The following is a description of a gene set: Human Gene Set: GSE3982_EOSINOPHIL_VS_CENT_MEMORY_CD4_TCELL_DN studied in species Homo sapiens Genes down-regulated in comparison of eosinophils versus central memory CD4 T cells. from publication Jeffrey KL, Brummer T, Rolph MS, Liu SM, Callejas NA, Grumont RJ, Gillieron C, Mackay F, Grey S, Camps M, Rommel C, Gerondakis SD, Mackay CR (PMID 16474395) In the present study we used Affymetrix oligonucleotide microarrays to produce gene transcription profiles for the major leukocyte types in humans. This comprehensive dataset enabled us to not only establish which genes were expressed in each leukocyte type, but also which genes were expressed in each subset after activation. The used of a comprehensive dataset of gene profiles from all the major human leukocyte subsets enabled a novel and powerful means for identification of genes associated with single leukocyte subsets, or different immune paradigms., and this is the list of marker genes: PHB1, CUL4A, ZNF32, RAB40A, TMEM62, CETP, THAP12, CCHCR1, COX16 (cytochrome c oxidase assembly factor COX16), MALT1, GFOD3P (Gfo/Idh/MocA-like oxidoreductase domain containing 3, pseudogene), ABCA3, IL27RA, CMTR1 (cap methyltransferase 1), ANXA6, GIMAP6, NOC3L, SKIC3, POLI, RPS17, TRIM46, USP21, DPP4, UBE4B, CLUAP1, PELP1, HSP90AA1, DOCK9, CAPNS1, APBB1, MCM3, CBLB, ITGB1, SDC4, ADD3, CD38, TMSB10, COQ3, IL17A, TCF12 (NCBI Gene Id 6938), MRPL39, PKD1P1, RACK1, UQCRC2 (ubiquinol-cytochrome c reductase core protein 2), CASP8AP2, IL10RA (NCBI Gene Id 3587), RABGAP1, PFAS, KPNA6, CASK, DPY19L2P2, PEA15, CIZ1, HIGD2A, CUL2, PUS7, TTK, TCOF1, RPL26 (ribosomal protein L26), CYB561, RPL13A, URI1, FOLR2 (NCBI Gene Id 2350), TRIM14, MRPL34, MAP3K4, AGPAT5, BOK, FERRY3, CTSH, ZNF318, INTS8, PWP1, DAP3, DHRS3, CD320, ZMYND8, LDLRAD4, RPL7, ZBED5, MRPL24, COPZ1, TMEM63A (NCBI Gene Id 9725), MRPL3, CBX5, DDX18, TFG, NIPSNAP1, F8, KCNH6, HJURP, NFYB, INVS, HOXB8, PRPF38B, PAM, NUDT1, LIMA1, ZNF544, COPS7B, CAST, CARF, EEF1G, RPS21, SP3P, ABL1, CORO1B, HABP4, TOP2A, MTO1, ABCD4 (ATP binding cassette subfamily D member 4), CBLN1, KLHL23, DPAGT1, PNP, DEK, LTBP3, COX4I1, CAPN2, TMEM80, CUL1, DDX11, CD99, MICALL1, SYN3 (synapsin III), LRRC8D, SULT1B1, ATP6V1A, EIF2D, NSUN5, RMND1 (NCBI Gene Id 55005), UMPS, TARP, EHD3, HSPB1, PRKD3, UBE3C, GPA33, TRAM1, RPL22, IL6ST, EIF2B5, HSPA8, IGHV5-78, ITPR3, NOSIP, SIDT1, RPS16, LZTFL1, IARS2, BLMH, CRYBA4, DZIP3, TMEM204, CAND1, TNFSF11, CAMTA1, TMEM134, LCK, DLG3, CD28, GEMIN8, GFUS, ITIH1, MYOC, SEMA4C, RAD17, IRF4, GARRE1, RPL36, CHN1, DUSP8, ZNF80, COPS6, VILL, MSMO1, NELFA, PLEKHO1, TXN2, PIK3C2B, TRIAP1, GRSF1, FXR1, ERBB2, NAP1L4, PPRC1, NACC2, PERP, TRIB2, NR2E1, CCDC25, FHIP2B, MANEA, STEAP1, SESN1, PASK, SEPTIN10 (NCBI Gene Id 151011), MRPS33